The following is a description of a gene set: Reactome Pathway: Cell Cycle Checkpoints This event has been computationally inferred from an event that has been demonstrated in another species.<p>The inference is based on the homology mapping from PANTHER. Briefly, reactions for which all involved PhysicalEntities (in input, output and catalyst) have a mapped orthologue/paralogue (for complexes at least 75% of components must have a mapping) are inferred to the other species. part of: Cell Cycle electronically inferred by orthology from the curated human pathway species: Mus musculus, and this is the list of marker genes: H2bc27, Orc3, Psma7, Cenpn, Psmb7, Nup85, H4c8, Ccnb1, H2bc15, Ndc80, Chek2, Psma5, Csnk1e, H2ax, Cdc23, Cdc25c, Wrn, Mdc1, Csnk1a1, Kif2c, Psmc5, Psma6, Ppp2r5b, Rad9a, Orc1, H4c18, Rad1, Plk1, Cul1, Gtse1, Phf20, Psmd6, H2bc8, Kif2b (kinesin family member 2B), H4c17 (H4 clustered histone 17), Nup133, Spc24, Zwilch, H4c14, Ppp2r5a, Psma2, Psmc3, Nde1, Nbn, Psmd12, Ccne2, Psmb4, Psmd1, Cenpm, H4c9, Ube2e1, Ccne1, Psmc4, Pias4, Wee1, Brcc3, H4c6, H2bc1, Zfp385a, Cdc7, Psmc1, H4c12, Kntc1, Sfn, Cdc6, Top3a, Cenps, Nudc, Psma1, Ppp2r5d, Rfc3, Cenpt, Ube2d1, Cdc26, H2bc22, Brca1, H4c3, Cenpu, Anapc15, Seh1l, H4c4, Orc5, Babam1, Aurkb, Trp53bp1, Ube2n, Blm (NCBI Gene Id 12144), Mad2l1, Psmd13, H4c11, Clasp1, Mis12, Mcm2, Mcm8, H2bc11, H2bc7 (NCBI Gene Id 319180), Mad1l1, Psmb5, Psmc6 (proteasome (prosome, macropain) 26S subunit, ATPase, 6), Ppp2r1b, Mapk11, Kat5, H2bc9, Ywhah, Cdc45, Ube2s, Ska1, Dbf4, Cdkn1b, Dync1li2, Dynll1, Rnf168, Mcm4, H2bc13, Anapc10, Hus1 (NCBI Gene Id 15574), Anapc7, Ube2c, Itgb3bp, Bard1, Nek11, Mcm7, Rpa1, Xpo1, Cdkn1a, Dna2, Mapk14, Anapc2, Psmc2, H4c2, H4c1, Ndel1, Orc4, Ccna1, Psmb6, Psmd7, Cenpq, Ywhae (NCBI Gene Id 22627), Psma4, Rps27a (NCBI Gene Id 78294), H2bc12, Cdk1, Rbbp8, H2bc3, Ubb (NCBI Gene Id 22187), Cenpe, Mre11a, Trp53, Cenpa, B9d2, Psma3